The following is a description of a gene set: Genes predicted to be targets of miRBase v22 microRNA hsa-miR-6510-5p in miRDB v6.0 with MirTarget v4 prediction scores > 80 (high confidence targets). studied in species Homo sapiens Human Gene Set: MIR6510_5P from publication Chen Y, Wang X (PMID 31504780), and this is the list of marker genes: MAP1A, NOP9, TRMT61A, CDK16, EFS, KCNS1, PTGER3, HYKK, SLC25A17, REEP2, PGF, SIPA1L1, RANBP6, FOXO4, ABCA2, PPP1R3D, IKBKB (NCBI Gene Id 3551), WNT3 (Wnt family member 3), SEPTIN4, DNAI3, URM1, IKZF5, TMOD2, ELOVL4, TGM2, HMBOX1, NFAM1, ZNF704, SLC27A1, TFG, RCC1, SLC23A2, LAMTOR1, PDRG1 (NCBI Gene Id 96818), VSIG4, IFFO1, VSNL1, G6PC3, TNFAIP1, LARP1, SALL1, ZNF213, CHMP5, ABR, PHYHIP, PDE7B, SZRD1, SEC24C, GRAMD2B, ZBTB20, USP24, PHF21A, TOM1, ACSL1, TUBGCP4, GABRE, ZMAT3, PAFAH1B1, RNF122, BAZ2A, STX7, IL22, NAP1L1, LTF, TP53BP1, SLC7A10, SIGMAR1, IQSEC3, RSPO4, LDLRAP1, LMNA, ERC1, NCDN, FXYD6, MAFB, LYPD8, MAPK1, CDC34, ALX4, FOCAD, MRTFA, RAPGEFL1, GPC6, SLC38A3, FGFR1OP2, BPTF